The following is a description of a gene set: from publication Wang J, Iwasaki H, Krivtsov A, Febbo PG, Thorner AR, Ernst P, Anastasiadou E, Kutok JL, Kogan SC, Zinkel SS, Fisher JK, Hess JL, Golub TR, Armstrong SA, Akashi K, Korsmeyer SJ (PMID 15635450) Top genes down-regulated in granulocyte/macrophage progenitors (GMP) upon expression of MLL-CBP fusion. Chromosomal translocations that fuse the mixed lineage leukemia (MLL) gene with multiple partners typify acute leukemias of infancy as well as therapy-related leukemias. We utilized a conditional knockin strategy to bypass the embryonic lethality caused by MLL-CBP expression and to assess the immediate effects of induced MLL-CBP expression on hematopoiesis. Within days of activating MLL-CBP, the fusion protein selectively expanded granulocyte/macrophage progenitors (GMP) and enhanced their self-renewal/proliferation. MLL-CBP altered the gene expression program of GMP, upregulating a subset of genes including Hox a9. Inhibition of Hox a9 expression by RNA interference demonstrated that MLL-CBP required Hox a9 for its enhanced cell expansion. Following exposure to sublethal gamma-irradiation or N-ethyl-N-nitrosourea (ENU), MLL-CBP mice developed myelomonocytic hyperplasia and progressed to fatal myeloproliferative disorders. These represented the spectrum of therapy-induced acute myelomonocytic leukemia/chronic myelomonocytic leukemia/myelodysplastic/myeloproliferative disorder similar to that seen in humans possessing the t(11;16). This model of MLL-CBP therapy-related myeloproliferative disease demonstrates the selectivity of this MLL fusion for GMP cells and its ability to initiate leukemogenesis in conjunction with cooperating mutations. Mouse Gene Set: WANG_TARGETS_OF_MLL_CBP_FUSION_DN species: Mus musculus, and this is the list of marker genes: Kpnb1, Tmed10, Ftsj3 (FtsJ RNA 2'-O-methyltransferase 3), G6pd2, Dlat, Ppic, Hars1, Pitrm1, Gm14296, Gabarapl1, Degs1, Irak1, Uxs1, Osbpl1a, Tomm70a, Fabp5 (fatty acid binding protein 5, epidermal), Rassf1, Cat, Naa10, Cwc22, Ttc27, Lactb, Ctsz (cathepsin Z), Tsc22d1, Ccnd2, Fgf23, Ggct, Ccdc86, Amot, Nipsnap1, Cul4a, Gtpbp4, Cpox, Ric8a, Selenow, Riox2, Strap, Tmem109, Dock8, Nrp1, Aldh7a1, Vdac1, Triap1, Glrx3, Psmc5 (protease (prosome, macropain) 26S subunit, ATPase 5), Nmd3